Given this list of marker genes Hpgd, Ptger4, Tfap2b, Stra6 (NCBI Gene Id 20897), Myocd, Foxf1, here is a description of the gene set: The morphogenesis process in which the ductus arteriosus changes to no longer permit blood flow after birth. The ductus arteriosus is the shunt between the aorta and the pulmonary artery which allows blood to bypass the fetus' lungs. studied in species Mus musculus Mouse Gene Set: GOBP_DUCTUS_ARTERIOSUS_CLOSURE